The following is a description of a gene set: The chemical reactions and pathways involving organic acids, any acidic compound containing carbon in covalent linkage. species: Homo sapiens Human Gene Set: GOBP_ORGANIC_ACID_METABOLIC_PROCESS, and this is the list of marker genes: AWAT1, SLC27A3, MFSD2A, ALDH3A2, TWIST1, GATD1, CEACAM1, PTGDS, DLD, MIR182 (NCBI Gene Id 406958), CYP2R1, ACOX3, PRMT3, PTGES2, ATP7A, MIR132 (NCBI Gene Id 406921), NUPR1, ANGPTL3, QKI, RDH10, PCK1, ACLY, ABHD1, DAOA, CES2, ADH1B, UBR4, PC, FABP2 (fatty acid binding protein 2), BCKDHA, ZBTB7A, ACADSB, SLC16A3, NCOR1, ACAD10, ACAD11, ACAT1, ECI1 (NCBI Gene Id 1632), HTR2A, PIBF1, GHR, LTA4H, PRKAA2, FLCN, GLYAT, MPST, AOAH, PTER, BHMT, HPD, SLC34A1, DHFR, PDK4, ABHD5, TMEM135, AVPR1A, ACOT7, SDS (serine dehydratase), PEDS1, PKLR, LIPG, NDP, IRS2, ME3, ACBD7, GHSR, NR5A2, CYP27C1, BTD, PLP1, CYP26A1, SRR, CTH, AGMAT, MAT1A, PYCARD, ACSF2, MIR204, AASDH, HADHA, PGK1, SLC19A1, GSTM4, MIR21, ACOT12, CYP2W1, NR1H2, SLC4A4, ABCB11, HLCS, PGAM1, SULT1C4, QPRT, SLC27A2, ETFA, PFKFB2 (NCBI Gene Id 5208, 6-phosphofructo-2-kinase/fructose-2,6-biphosphatase 2), AKR1D1, GPT, PRKAG1, VNN1, MIR30C1, GCK, SLC35A1, ALDH1A1, GGT7, INS, ACADS, LPGAT1, HMGCLL1, THAP4, EDN2, SLC45A2 (NCBI Gene Id 51151), MIR33A, ASPA (NCBI Gene Id 443), TIGAR, ACOX1, GLDC (NCBI Gene Id 2731), GIT1, CBR4, PLA2G15, ACOXL, PGAM2, NR1H4, PTGES, DECR2, ADH6 (alcohol dehydrogenase 6 (class V)), COL6A1, OSBP, HSD17B10, PPARGC1A, HSD3B7, MALRD1, PYCR2, HK2, AKT1, MGST2, PAPSS2, MTARC2, DHFRP1, APOA4, GAMT, ATF4, HADH, GALK1, ECHDC2, ALDH5A1, PDHA2, GLYATL1B, ALDH1A3, AKT2, ALOXE3 (NCBI Gene Id 64048), ACOT6, ETFDH, TYRP1, NADSYN1, ABCD2, GAD2, HIF1A, SLC38A8, TST, SLC27A4, CYP46A1, CRAT (carnitine O-acetyltransferase), TECR, CS, UGT1A6, ALOX12B, RIDA, KYNU, DAO, SUCLG2, MIF, ECHS1, THNSL2, FMO2, IYD, MMUT (methylmalonyl-CoA mutase), OAT (NCBI Gene Id 4942), GCSH, ACOT2, FABP5, ADH4, CYP4B1, SULT1E1, PEX7, TPH1, EP300, NUDT19, ACBD4, RPTOR, BCAT1, FASN, PRKAB2, LDHAL6B, DAGLA, ABCC10, PRODH2, PDHB, NAIP, SULT2A1, GAD1, UGT1A10, EIF6, ARV1, GLUD2, PNLIPRP3, ELOVL5, CPA1, SLC2A3, HIBADH, MGLL, GNMT, OSBPL3, AGXT, ASRGL1, CARNMT1, PNPLA8, ACOT1, ACSL1, HACD2, SLC27A1, ENO1, EGLN2, SRC (SRC proto-oncogene, non-receptor tyrosine kinase), KYAT1, SIRT1, SLC16A1, ALOX15B, UGT1A4, UGT1A7, HDC, LIPF, CYP2A13, SIRT2, AACS, ELOVL6, HDAC4, DHTKD1, ALDH8A1, ACSL6, UGT2A1, LPIN3, CYP39A1, AFMID, FADS2, BAAT, INSR, ECI2, ALDOA, HACD3, FH, JMJD8, ACOT11, ENO2, LIPC, PGK2, PLA2G4D, UGDH, ENSG00000274276, ANKH, MIR342, HIBCH, PROX1, SLC23A2, STARD4, PCCA, XBP1, DAGLB, SDHAF3, GGT6, ME1, EPHX1 (NCBI Gene Id 2052), ASNSD1 (asparagine synthetase domain containing 1), MCAT, HACD1, MCEE, AMDHD1, CYP2J2, GSTA1, ARG2, HPGDS, SIRT6, ATP1A2, DEGS1, PLOD3, APP, OGDH, LPL, HYKK, KGD4, CYP4Z1, FOXK2, HSD17B8, CYP4A11, DDC, GLUL, FAAH2, CDO1, MTHFS, INSIG2, PLA2G10, PAH, MLYCD, HSD17B4, NUDT8, GGTA1, GCDH, HAL, ENPP1, GIP, GPX1, ALDH1L1, DDAH2, TBXAS1, AKR1C2, GSTO1, DLAT, LYPLA1 (NCBI Gene Id 105375839), UEVLD, ACOT8, CYP4F12, ACAD8, OGT, OLAH, GCLM, HNF4A, UCHL1, PRKAG2, PEX5, PGD, TNFRSF1A, ETFBKMT, PECR (peroxisomal trans-2-enoyl-CoA reductase), UGP2, CSAD, IER3, PIPOX, NOXRED1, DPEP1, HAGH, DDAH1, ALOX5, ALDOC, SULT1B1, PRG3, CYP1A2, GAPDH, ENSG00000293349, AASS, FOXK1, PLOD2, HNMT, ERO1A, HYI, OGDHL, CYP27A1, LDHD (NCBI Gene Id 197257), ATP8B1, AKR1C4, MFSD8, THEM4, PRKAG3, CYGB, HAO2 (NCBI Gene Id 51544), LDHC, LTC4S, GPIHBP1, ADPGK, P2RX7 (NCBI Gene Id 5027), MDH2, SEPHS2, TREX1, SLC27A6, PRXL2B, CAD, KLHL25, EDN1, ACSBG1, ABCC1 (NCBI Gene Id 8133), GBA2, BPNT1, NFE2L1, AKR1C3, PPM1K, ANGPTL4, STAT5A, PANK4, OSBPL1A, BCKDK, MORC2, ACSM2B, TPH2, SRD5A2, ABHD14B, UGT1A3 (NCBI Gene Id 54659), ARHGAP11B, CYP2C9, UGT2A2, ALDH18A1, OTC (NCBI Gene Id 5009), PFAS, MSMO1 (NCBI Gene Id 6307), CLSTN3, BCO2, ASAH2, COMT, FADS3, NPC1, FPGS, BDH2, DCXR, PRODH, PNLIPRP2, TRIM63, PLA2G2F, ALOX5AP, LIPA, HK3, ACSS1, ELOVL3, GSTO2, LPO, AZIN2 (antizyme inhibitor 2), AZIN1, RBP1, ATCAY, NDUFS6 (NCBI Gene Id 4726), PGAM4, PLA2G4B, IDO2, GGTLC1, ARL2, DECR1, GGTLC2, MIR766, ACMSD, CSGALNACT1, ACAA1, SOX9, ASL, SUCLA2, SESN2, ANKRD23, OXSM, ADIPOR1, NDUFAB1, BLMH, ALKBH7, GGT3P, POR, TDO2, MGAT4A, PDK1, NR1D1, MTHFR, KMO, ACTN3, PPARD (NCBI Gene Id 5467), CAV1, FOLR1, NAAA, CYP2C8, GOT1, HAO1, N6AMT1, TH, IVD, APOC2, CYP2E1, SLC5A6, GPAM, SP7, TPI1, ACSL3, ADH7, GOT1L1, CYP2F1, SDSL, THEM5, HOGA1, CRYL1, FAHD2B, ACSF3, DHFR2, FN3K, MRS2, FGFR4, TECRL, CYP7A1, PRKAB1, FAHD2A, NOS3, SLC2A6, FMO4, GNPDA2, STAT3, CASP1 (caspase 1), SLC25A42, SELENON, UGT1A9, UGT1A1, GLUD1 (NCBI Gene Id 2746), CYP2A7, DCT, STAT5B (NCBI Gene Id 6777), WDTC1, CYP3A4, SNCA, MIR96, SLC45A3, RENBP, PFKFB1, CD36, MTHFD1L, PFKM, CTHRC1, LYPLA2, SREBF1 (NCBI Gene Id 6720), ENO3 (NCBI Gene Id 2027), ATIC, SLC27A5, MCCC2, MECR (mitochondrial trans-2-enoyl-CoA reductase), UCP2, PKM, HSD17B12, PSPH, FBP1, ELOVL7, TYR, PON3, PTGR1, ABCC9, ACSS2, CYP2D6, LPIN2, CD74, ETFB, ASAH1, PHYH, MIR185, NAGS, CYP4A22, FMO3, GGT2P, APIP, APOC1, ERFE, FAAH, MTHFD1, LDHB, NAALAD2, ADSS1, SULT1A3, MECP2, CBS, ASS1, LONP2, IDH3B, CYP2C18, FAHD1, CYP1A1, DGAT2, CYP3A5, ABHD12 (NCBI Gene Id 26090), MAPK14, BRCA1, FADS1, HMGCL, PRKAA1, SHMT2, DDO, ALDH1A2, CYP8B1, ALDH1L2, FABP3, OSBPL6, ARNT, OSBPL7, CBFA2T3, SCAP, PPARG, ABCD4 (NCBI Gene Id 5826), PLA2G4C, MSRA, PARK7, GLS2, PFKL, CYP1B1, MIR548P, DCAF5, HGD, BLOC1S6, SCD5, SEPHS1, GPI, SULT1A2, ACBD5, MID1IP1, HPGD, ALDOB, IDH1, DBT, MTHFD2, MIR210, PRXL2C, AUH, ABAT, NCF1, QDPR, MTARC1 (NCBI Gene Id 64757), CYP2B6, ADH5, ALDH6A1, NANP, UROC1, IL4I1, MTRR, ACADM, ADIPOR2, ZBTB20, ACAT2, HACD4, PDK3, ST6GAL1, DHRS9, SCLY, KAT2B, PSEN1, MLST8, ATP2B4, MBLAC2, DPEP2, FGFR1, CROT, ABCD1, MTR, DPYD, IDH2, ACSL4 (NCBI Gene Id 4426), BPGM, PTGIS, D2HGDH, DBI, SLC25A32, L2HGDH, GSTM1, PLA2G1B, ACSM4, VNN2, ALDH4A1, PNLIPRP1, CPT1A, AGXT2, CPT2, CYP3A7, SLC25A2, PNPLA3, PER2, OSBPL2, SDHA (succinate dehydrogenase complex flavoprotein subunit A), CYP26B1, MGST3, CRYM, ERRFI1, IDH3A, CES1, PLA2G3, ENOPH1, IRS1, ABHD3, CYP2S1, ACOX2, AMDHD2, MPO, ART4, TRIB3, SDHB, ECH1, ST3GAL1, GNE, SLC25A44, MTLN, ECHDC1, PNKD, ABCD3, ASPG, SULT2B1, BCAT2, ERLIN1, ACOT4, MDH1B, GOT2, ACO2, KYAT3, AKR1C1, SULT1A1, INSIG1, GRHPR, GPX4, CYP26C1, PHGDH, SLC22A13, MTOR, CMAS, PANK2, SYK, HAAO, NPL, SLC25A17, AS3MT, PRKAR2B, TPST2, CYP4V2, SORD, GNPDA1, GGTLC3 (gamma-glutamyltransferase light chain family member 3), ENO4, MDH1, PCBD1, ADSS2, ADH1A (alcohol dehydrogenase 1A (class I), alpha polypeptide), PM20D2, ACSM3, ACSM6, PM20D1, TYSND1, ACAA2, IGF1, ERLIN2, SLC4A1, GADL1, LGSN, MPC2, PEX13, CYP2A6, CPT1C, NLRC4, ELOVL4, NOS2, GCLC (glutamate-cysteine ligase catalytic subunit), PCK2, ACO1, SLC2A1, SMS, LDHA, ABHD2, CARNS1, ACSM1, CYP2U1, SLC7A11, CYP4F3, FAH, ADIPOQ, PYCR3, PLIN5, AIG1, MTHFD2L, ACADVL, TPK1, CPT1B, SULT1A4, PLAA, BHMT2, MCCC1, OCA2, SLC25A21, HADHB, FKRP, ABHD6, TNXB, ASNS, IFNG, CBR1, PLA2G4A, IL1B, HACL1, AVP, RIMKLA, NANS, FGF19, PDHX, CLN3 (CLN3 lysosomal/endosomal transmembrane protein, battenin), PYCR1, GPAT4, PAPSS1, GLYATL1, ACOT9, ADH1C, AKR1A1, APOA5, EHHADH, CYP4F11, CYP7B1, FADS6, GSTZ1, GSTP1, CYP4F2, PFKP, UCP3, ACSM5, HK1, PPA2, PTGES3, CYP4F8, ACADL, PPP2CA, SGPL1, ACSL5, PFKFB3, FTCD, NOS1, RIMKLB, FA2H, GLS, MTCH2, SHMT1, ELOVL1, PDK2, VDAC1 (voltage dependent anion channel 1), PSAT1, ODC1, SERINC5, FADS2B, LPIN1, P4HB, PNLIP, GGT1, PEX2, ACAD9, SLC7A7, NUDT7, BPHL, ELOVL2, SLC46A1, PPARA (peroxisome proliferator activated receptor alpha), SULT1C3, TTC36 (tetratricopeptide repeat domain 36), CYP2C19, UPB1, AMT, TAT, SLC23A1, PTGS2, SLC6A8, AKR1B1, HTD2, ARG1, SCD, PLA2G4F (NCBI Gene Id 255189), LEP, DGLUCY, GATM, AASDHPPT, TP53, DLST, STAR, UGT1A8, NR1H3, NOX4, SLC1A3, ICMT, C3, ADI1, BCKDHB, UROS, KIT, APOC3, ALOX15, LIAS (NCBI Gene Id 94182), NAT8L, ADHFE1, IDO1, SCP2, SARDH, TPST1, ME2, OSBPL9, ATP6V1B1, LDHAL6A, ACACA, PLA2G5, PDXDC1, IDH3G, DDIT4, HKDC1, SLC25A16, SLC39A8, AADAT, PTGS1, GPD1, GAPDHS, GCAT, NAGK, CYP4F22, ACSBG2, SIRT4, NIT2 (NCBI Gene Id 56954, nitrilase family member 2), XYLB, PRKACA, CPS1, GDF15, ACACB, ILVBL, ECHDC3, SCPEP1 (NCBI Gene Id 59342), MLXIPL, FMO1, PON1, CRABP2, MAPKAPK2, HPDL, APPL2, PCCB (propionyl-CoA carboxylase subunit beta), AMACR, GSTM2, PTGR2, SLC38A1, PDXDC2P-NPIPB14P, PDHA1, BCL2L13, GPT2, PGM1, ACSM2A, GGT5, GLYATL2 (NCBI Gene Id 219970), ADTRP, SERINC3, ALOX12